The following is a description of a gene set: from publication Yevshin I, Sharipov R, Kolmykov S, Kondrakhin Y, Kolpakov F (PMID 30445619) Human Gene Set: ZNF202_TARGET_GENES studied in species Homo sapiens Genes containing one or more binding sites for (ZNF202) in their promoter regions (TSS -1000,+100 bp) as identified by GTRD version 20.06 ChIP-seq harmonization., and this is the list of marker genes: ELOVL2-AS1, TUBA1C, EBF1, HEBP2 (NCBI Gene Id 23593), RWDD4P1, BBX, HAPLN4, RHBDD1, TUBGCP3, FAM177A1, ITGAL-AS1, BAIAP2L1, TRIM15, BRINP3-DT, EXOSC2 (NCBI Gene Id 23404, exosome component 2), HAPLN2, TDRD12, RAI14, CCNG1, CPEB1, SEC62, ZNF358, SNAP25, RND1, SLC6A1, SDC4, HHATL, ZNF280D, UBE2Q2P13, MIR4428, ASS1P5, PRKAG2, ZDHHC17, FAM168A, IL20RA, FES, CPEB1-AS1, NOL6, ADA, PDE7A, FHL1P1, LINC02202, SNHG30, RFX4, SOBP, PDE7A-DT, PRKD1, NR2F1-AS1, ETS2, CD160, ELOVL2, COPS3, PLCL2, ALDOA (aldolase, fructose-bisphosphate A), NCKAP1L, NAPSA, MDFIC, RRN3P1, EZR, FMN2, TRIP12, VANGL1 (NCBI Gene Id 81839), FCHO2, BRINP3, WTIP, CWC25, HOXA2, CCSER1, BORCS6, LINC00567, NLE1, TNFRSF11A, EBPL, PCDH17, TTC1, OR1X5P, GGACT, SCN3B, MTO1, TLX1, SYCP2, NPAS3, RNU6-826P